Given this list of marker genes PHF21A, OPHN1, KLHL24, TAOK3, ATP1A3, ANKRD12, MAN2B1, SMAGP (NCBI Gene Id 57228), SDF2, APOBEC1, CEP97, ARL4C, CEBPG, KIF22, TNFRSF13B, VEZF1, RANBP9, ARHGAP6, RNF114, BOD1L1, ATRX, ZNF277, KBTBD2, KMO (NCBI Gene Id 8564), GPCPD1, AKIRIN2, RPS27, TAB2, EIF3F, MED31 (NCBI Gene Id 51003), CNRIP1, RASA1, GNPDA1, SLC66A2, ITM2C, HIGD1C, PLXDC2, TMEM9, PDE7A, TBC1D12, APOE, PLXNB3, CROT, RAPH1, PKIG, CCR5, MPP1, UBN1, FAM8A1, SASH1, GPR146, CDCA2, C3AR1, FAM174A, ZFAND4, PIMREG, SOCS7, ACD, ASNSD1, TMEM127, CENPA, ELOA, PRXL2C, GRINA, GANC, ARHGEF3, RIPOR1, MYLIP, ALDH9A1, YPEL3, SURF1, DOCK8, NMT1, INSR, USP45 (NCBI Gene Id 85015, ubiquitin specific peptidase 45), ANGPTL4, MFSD11, RSRP1, FGD4, SGMS1, CH25H, ID2, EXOC6, ATP5MC2, TPRG1L, TIAL1 (NCBI Gene Id 8430), CEP57L1, EVI2B, MOK, MFGE8, MEGF8, CAMK1, CDKN3, MARCHF7, MTHFS, GAS6, AP1S2, POLR3GL, FAM107B, GKAP1, PURA, TNRC6B, TBXAS1, APH1B, MECP2, CACFD1, LIN37, YPEL2, CASP3, TUT7, MAPRE2, CCNB2, SFT2D2, SAMD4A, MBD4, GCNT1, FNIP1, RPL7, AKAP10, PIP4K2A, RIN2, MKNK2, CLK1, RERE, HEATR5A, SEC62, TCTN3, DHRS7, RAPGEF6, STAMBP, MMD, REPS2, OSBPL11, ZZZ3, FEM1C, SPOP, CEP55, CTDSP2, TLE2, PURG, SLC16A4, MIB2, CDKN2C, ZFHX3, IL16, SMC4, MXI1, NCOR2, MTMR3, KIF2C, KDM2B, ARID1A (NCBI Gene Id 8289), STX5, BLMH, KMT2D, UBQLN2, CDK17, TOP1, CCNG2, PCNT, NIPBL, AURKA, CIP2A, CAMK1D, RNF167, FOXO4, FCHO2, RASSF5, RABGAP1L, SIRT7, RORA, ZRANB3, FBXO25, RASGEF1B, IFTAP, ANKRD26, NKIRAS2, CYP4F3, PLK1, THBD, TP53INP1, CTSA, GPR155 (NCBI Gene Id 151556), ABCG2, SGSH, FYN, EXOC4, KIF9, MEF2A, RAMAC, ERN1, AKAP13, SESN1, CKB, CDS2, NAGA, DYRK3, TTC17, SIRT2, C9orf78, here is a description of the gene set: Genes up-regulated in CD8 T cells: control versus stimulated by IFNA5 and activated by anti-CD3 and anti-CD28. studied in species Homo sapiens Human Gene Set: GSE17301_CTRL_VS_48H_ACD3_ACD28_IFNA5_STIM_CD8_TCELL_UP IFN alpha mediated gene expression pattern. The effect of IFN alpha on human CD8 T cells responding to antigen (signal 1) and costimulatory signals (signal 2) provided by beads coated with anti-CD3 and anti-CD28 mAbs. This analysis examined the effects of IFN alpha on human CD8 T cells responding to antigen (signal 1) and costimulatory signals (signal 2) provided by beads coated with anti-CD3 and anti-CD28 mAbs. Magnetically sorted untouched CD8+CD45R0- T cells from three different donors were unstimulated or stimulated with IFNa2b or with anti-CD3/CD28 Beads alone or along with IFNa2b or IFNa5 for 48 hours. Individual mRNA samples were analyzed using HG-U133A 2.0 array gene chips. from publication Hervas-Stubbs S, Riezu-Boj JI, Gonzalez I, Mancheño U, Dubrot J, Azpilicueta A, Gabari I, Palazon A, Aranguren A, Ruiz J, Prieto J, Larrea E, Melero I (PMID 21108462)